Given this list of marker genes MYO1F, ZBTB24, MUC2, MT1M, REG4, HEPACAM2, ERN2, NEURL1, ACSS2, STARD10, TSPYL5, SYP, TFF1, CLCA1 (chloride channel accessory 1), PLEKHG6, GRPEL2, REP15, MAGEF1, VAMP4, GSTCD, CFHR4, ESR1, PAX3, ABCA4, RNASE1, SPINK4, ATAD5, ST6GALNAC1, KLK1, SPDEF, CENPM, LINC01994, KRT19, GAU1, FAM3B, SRP72, BCAS1, FAM193B, STXBP5-AS1, C8orf44, CCDC160, MCM3AP-AS1, GSN, MSANTD2, FCGBP, FUT6, here is a description of the gene set: Human Gene Set: GAO_SMALL_INTESTINE_24W_C6_GOBLET_CELLS studied in species Homo sapiens from publication Gao S, Yan L, Wang R, Li J, Yong J, Zhou X, Wei Y, Wu X, Wang X, Fan X, Yan J, Zhi X, Gao Y, Guo H, Jin X, Wang W, Mao Y, Wang F, Wen L, Fu W, Ge H, Qiao J, Tang F (PMID 29802404)